The following is a description of a gene set: studied in species Homo sapiens Human Gene Set: HP_LEFT_VENTRICULAR_NONCOMPACTION_CARDIOMYOPATHY Left ventricular non-compaction (LVNC) is characterized by prominent left ventricular trabeculae and deep inter-trabecular recesses. The myocardial wall is often thickened with a thin, compacted epicardial layer and a thickened endocardial layer. In some patients, LVNC is associated with left ventricular dilatation and systolic dysfunction, which can be transient in neonates. Left ventricular noncompaction cardiomyopathy, and this is the list of marker genes: RYR2, MIB1 (MIB E3 ubiquitin protein ligase 1), CRLS1, NONO, TPM1, TBX5, MLYCD, DTNA, MYL2, MYOCD